The following is a description of a gene set: from publication Yevshin I, Sharipov R, Kolmykov S, Kondrakhin Y, Kolpakov F (PMID 30445619) Genes containing one or more binding sites for (SRSF9) in their promoter regions (TSS -1000,+100 bp) as identified by GTRD version 20.06 ChIP-seq harmonization. Human Gene Set: SRSF9_TARGET_GENES studied in species Homo sapiens, and this is the list of marker genes: POLN, SMC3P1, FBXO4, C2orf74-AS1, SNORD12, SNORA57, WAC, HCG15, CEP112 (centrosomal protein 112), ZFYVE16, RAD18, TXNDC9, LINC01089, VPS52, PRR11, TUBE1, KDM7A, RNY1P10, EMB, ANKRD66, ARSG, SPO11, RPS17P7, LUC7L3, DEK, MT-TC (NCBI Gene Id 4511), RNU4-75P, RN7SL638P, ACSM3, ZNF638, DTNB, IFT80, CENPK, ACIN1, RNU1-109P, NUSAP1, KRTAP1-3, GORASP2, FCHO2-DT, CYP27A1, PTPRK, DENND4A, PGBP, CNOT4, CDH8, HISLA, RNU6-1153P, RNU4-84P, RN7SL700P, TIA1, FOXG1, PLK4, IGLV3-4, NIF3L1, ANKRD44, GPATCH8, MAP2K6, EIF4B, NARF, RN7SL162P, ATP6V1G2, CSRNP3, TTL, ZNF680, COL21A1, CYP3A43, IFI44L, LINC00540, SETDB1, ARMT1, RPS2P48, RN7SL577P, RAD51B (NCBI Gene Id 5890), LTBP1, TXNL4AP1, KLHL31, SNORD117, ENSG00000201003, FKTN, LINC00972, SUPT20H, ZFYVE1, METTL8, SEC63P1, GS1-204I12.4, MIR4295, OXA1L, PSMD1, CACNA1I (calcium voltage-gated channel subunit alpha1 I), ENSG00000213963, CRKL, CLASP2, MT-CO2, RNU6-784P (NCBI Gene Id 106481428), IQUB, NOVA1, MSH2, CLSPN, TMBIM6, MIR100HG, ENSG00000235779, RN7SL510P, SYNE1, HECTD1 (HECT domain E3 ubiquitin protein ligase 1), DUSP5P1, XPO6, CAB39L, SCN3A, CCDC28A-AS1, CHTF8, TRAV32, KMO, MIR3156-1 (microRNA 3156-1), KRT8P43 (NCBI Gene Id 100293614), LINC01932, ETAA1, GPER1, SPAG16, RBM26, EGLN3, TTC21B, AHSA2P, TUSC3, SNX29, JAM2, EGFEM1P, SEPTIN1, NXPH1, LITATS1, A2M, FRMD6, TMEM123, MROH2A, SAP130, NDUFAF7, MIR340, LINC02032, LRRK2, OR2AP1, HMGN2P6, ASPH, STK38, ANGPTL4, ADAT2, HSPD1P13, DUSP22, MIA2, BAK1P1, TNPO2, MARCHF7, RNU1-101P, RPGRIP1, IRAG2, TRIM25, HECTD2, REV1, BCL2L2, GAS5, RPL36AP38, ARHGAP24, PPP3R1, MCEE, HMGN2P46, TTC29, TIAL1, RPL21P26, LINC02814, RNF212B, C12orf42, KBTBD6, FDFT1, NBAS, RNU1-131P, TRAPPC12 (trafficking protein particle complex subunit 12), CTNNB1, SNORA70 (NCBI Gene Id 26778), GCFC2, CEP170, FA2H (NCBI Gene Id 79152), RAPGEF2, GNL2, TNPO1, MIR1972-1, OR7E13P, PIRAT1, CDK5RAP2, MTRF1L, EPC2, ENOPH1P1, VPS26CP1, TUBAP13, OR2T4, FCF1P6, OR4F15, ATG12, ERI2, METTL23, ABHD4 (abhydrolase domain containing 4, N-acyl phospholipase B), MLIP-AS1, CNTLN, RFPL1S, TC2N, DHRS2, ARHGAP5, SGCA, LIMS2, MALAT1, IMPDH1P7, SRBD1, BCAS3, DICER1, RPL22P1, LRBA, R3HDM1, CARD6, MTCO3P12, MTA3, NOVA1-DT, MT-TT, SMIM14-DT, LRP1B, BCL2L2-PABPN1, LRP3, NOP58, ROCK2, MT-TR, DSG1, ARHGDIA, RNU6-1136P, SF3B1 (splicing factor 3b subunit 1), CCNG1, CCND3, DSTN, XRN1, STK33, GIRGL, IGHV3-38, ASB5, MIR4424, PIKFYVE, FRY-AS1, RNF220, FAT3, RPS3AP11, SNAP25-AS1, CCNT2, TUBD1 (tubulin delta 1), FAM184A, GNG4, GLG1 (golgi glycoprotein 1), ENSG00000260277, LYRM4, PRRX1, SNORA59B, UBE3C, ITCH-AS1, MED6, KLRF1, OR4K15, TMPRSS11GP, SGIP1, UQCC1, PPIL3, SETP12, TAPT1 (transmembrane anterior posterior transformation 1), DCAF17, MT-ND5, ROBO3, CTAGE14P, RPL23AP70, ITSN2, ARHGAP26, EWSR1, FLACC1, VPS13D, C16orf87, RNU7-133P, RPS8P6, CDC42BPA, CLEC14A, SESN1, TAF5, RAP1B, IDNK, MTND4P26, KDM3A, NFKBIL1, SPART, SCN1A, NSMCE2, ITPR2, PPIEL, RBBP9, SLC25A32 (solute carrier family 25 member 32), ATP5MGP3, EPPIN, SC5D, FAM117A, RNF103, RPL31P30, HIBCH, BPHL, RNU6-75P, CD44, KCNMB3, DCN, CRYGGP (NCBI Gene Id 1424), GPRC5D-AS1, FTO, NF1P6, SNORD22, POLR2A, SLC25A27, RBM39, M1AP (meiosis 1 associated protein), LINC00310, SRSF10P2, RNA5SP145, ERICH3, PTHLH, UNC80, KRT223P, LINC00641, AKAP5, RNU6-812P (RNA, U6 small nuclear 812, pseudogene), MTRR, SLC10A5P1, MTIF2, HEATR5A, YWHAB, TMEM212-IT1, ACACB, DDX46, LPIN1, RNU6-445P, HEATR6, FIBCD1, ANKHD1, LRRC59, SEPHS1P6, RNU7-196P, RN7SL283P (NCBI Gene Id 106479325), PTPN9, SLC25A13, CEP83, SPTLC1P1, PDZD2, UNC50, ZC3H6, PCGF1, MTND3P10, USP8, HSBP1L1, MIRLET7F1, MKRN1, SEPTIN7P14, PLPP3, SLC38A10, ACOT13, OR2E1P, MDM4, CHD1L, ERCC6L2, POLE4, G2E3, OR11H7, ESPN, ENSG00000237464, MT-TE, LINC02458, TEX41, KRTAP7-1, SSB, CCDC34, NIBAN1, MICU2, RNU1-139P, CREB3L2, CLUL1, MIRLET7A1HG, POLR1D (NCBI Gene Id 51082), SPECC1L, BRCA2, DPRXP1, GTF2I, SETD5, RFX3, SNORD12B, ENSG00000283674, DRD3, MFSD11, GRIP1 (NCBI Gene Id 23426), HELZ, DLX2, EXOC4, SLC27A1, MT-TA, BIN2P2, GSDMA, NPM1P41 (NCBI Gene Id 100422249), LIFR, MPZL3, RNA5SP98, OCIAD1-AS1, TAF11, LRPPRC, SHC1, FST, RPL29P8, GAS2, YAF2, RNA5SP73, DTNBP1, STAU1, KIF28P, TEX14, DBF4P3, GAD1, CALR3, RHOBTB3, ILF2P2, TRIM37, STIL, OR4K5 (olfactory receptor family 4 subfamily K member 5), STRN, NOL11 (NCBI Gene Id 25926), NEXN-AS1, ASH2LP2, WDR54, FCHO2, DERA, TRAV3, RICTOR, MTND2P23, ICA1L, SNORA2C, KDM2B, KLF9, CHGB, TMEM237 (NCBI Gene Id 65062), LRP10, FMC1, TOX4, ATRAID, AGL, B3GALT1-AS1, NFE2L2, RIOK3, SMIM14, KRT19P6, ST7, MT-ND4, DMXL1, KCTD20, CLIC1, NCOA3, CLASP1, VPS50, SCPPPQ1, UNK, LINC03079, PROCR (NCBI Gene Id 10544), RUFY3, UBE2NP1, CYP1B1-AS1, PSMB5, TAF8, NDUFA5, LINC02354, ADGRF5, BRK1P2, RNU6-374P, OXA1L-DT, ATAD2, PHACTR2, ST3GAL3-AS1, MT-ND6, TRDN, MIR3974, STAT4-AS1, MNAT1, PTMAP1, NOX5, CHODL, CSE1L, NUP214, DIABLO, KCNK1, NEAT1, ZNF736P6Y, BAGE2, ZMYND11, YTHDC2, MTND4LP14, ZNF90, BFSP1, CCDC150, CANX, PCDH9-AS1, TRAV10, GTF2A1, BAZ1A, SPTBN1-AS2, DNAH6, ATP13A3, RSPH14, PLPBP, STAM2, PALMD, KIAA1328P1, LNCAROD, OR5AP2, EFHC1, RALGAPA1, CRYZL1, USP37, C2orf74, MIR3938, RPL7AP74, ARID5B, CCR10, SLC25A46, CSKMT, SLAMF6P1, MTREX, IGHVII-74-1, NGDN, RNU6-827P, SPDYA, PNPLA1, MIR4734, FN1, H4C2, C6, UTRN, CTNND1, RNA5SP483, MIR4307, OR4F6, ACKR4, FBF1, MT-TF, WDR43, BAZ2B, PAAF1, ZSCAN32, ITCH, CCNG2, MIR4477A, AP3S1, NUP98, PLA2R1, STPG4, POLR3E, MAP9, RMDN2, CAVIN2-AS1, UTP4, FABP5P4, M6PR, USF3, MAPRE1P2, MIPOL1, MT-ND3, LINC02890, PAIP1, TRAV25, PLN, NPIPB2, RNU6-636P, SKA3, TFB1M, TSHZ2, RANBP17, MINAR1, MYOM2, DDX42, FGFBP3, MTND4P25, MIR1302-3, EPB41L2, ZCCHC4, RN7SL269P (RNA, 7SL, cytoplasmic 269, pseudogene), LMAN1, MT-RNR1, PPP1R21, MIR449C, L3MBTL3, FGGY-DT, KBTBD2, RPL23AP36, AKR1E2, TXNDC16 (NCBI Gene Id 57544), GPM6A (glycoprotein M6A), TTC6 (tetratricopeptide repeat domain 6, NCBI Gene Id 319089), SESTD1, UQCRB, PDE4B, KLRG1, COX6CP8 (cytochrome c oxidase subunit 6C pseudogene 8), MAGEF1, PRMT7, NDUFV2, NPL, MDM2, TRAV8-4, NKTR, DPY19L4P1, PCBP1-AS1, VIRMA, TK2, FAM133EP, HNRNPA3P17, CENPN-AS1 (NCBI Gene Id 107984858), AIDAP1, CNTNAP4, CLTC, TMC4, DTYMK, SLC25A36, IL18R1, ADAM18, RN7SKP64, NDUFAF5, AZIN1, UBE2W, ZC3H7A, GEMIN2, SRP68, CENPC, LINC02265, MTND5P12, TMEM14B, SLC7A5P2, TTLL4, TRAF3IP2, UACA, FMC1-LUC7L2, ENSG00000228697, DYNC1LI2, GPC5, CCNL1, MLXIPL, RAD50 (RAD50 double strand break repair protein), MIR4804, RPL41, FMO5 (NCBI Gene Id 2330), PHGDH, GTF2A1-AS1, OR7H1P, ABCA5, ASB3, BTN3A1, ATR, ITFG1, CARHSP1, OR1L4, MTCO3P47, POP5, TRAV22, VPS13C, MLLT10, BVES-AS1 (BVES antisense RNA 1), HNRNPA1, MAILR, EML4, PCSK2, LINC01719, CFAP54, EYS, STAMBP, WTAP (NCBI Gene Id 9589), SYT17, ABCB1, ITGA4, RNU2-45P, MTCO1P17, USP3-AS1, KRTAP19-8, NARF-AS2, RBMS1, SCN2A, DYNC1I2, CACNA1A, USP53, HNRNPC, RPP30, USP34, PRL, TASOR2, ZC3H8, HCG22, LATS1, FARP2, SLC22A10, RPL31P28, MIR99AHG, WEE1, BRD7, CYLD, DAP-DT, SUMO4, DYNC1LI1, ZNF184, NSMCE1, C11orf98, ZFHX3, HNRNPA3, ENSG00000202335, TRPS1, RPL21P5 (NCBI Gene Id 641613), GNPAT, EHBP1, SKAP1-AS2, CPS1-IT1, TUT7 (NCBI Gene Id 79670), USP32, RPL21P62, PAXBP1 (PAX3 and PAX7 binding protein 1), TTN-AS1, PRKG1, MT-ND4L, SLC35F5, GSPT1, TINAG, NAA20, TRIB3, WDR59, CSN2, PPFIBP1, PDE3B, ACTG1P22, WWP1, ZNF133, EVI5, BPTF, PAPPA, RNU6-541P, RN7SKP83, BRCA1, CNOT7, MORF4L2, SYNRG, MTFR1, CUTC, MARK2P15, ZC3H12A, SIRT5, MTND5P11, SMG1P3, NLN, MANF, DOCK7, CKS1B, C6orf132, IL1RL1, SRP54, APOH, ZRANB3, HIP1R, FOXA1, FBXO9, CEP76, VPS29, UBE2E3, RNA5SP92, OPRL1, MBD5, IDH1, LINC02612, PDCD10, ATG12P1, CNTD1, CSNK2A1, AGXT2, CFLAR, TRPC4AP, LRRTM4, UGGT2, ETV1, ZNF846, TP53RK, RNU6-651P, BLCAP, PAPPA-AS2 (PAPPA antisense RNA 2), NEXN, DLL1, MAN1A1, MIR6812, MIR646HG, UBQLN1, UBA5, SMIM15P2, FAM32DP, ZMIZ1-AS1, PDE5A (phosphodiesterase 5A), MIR548E, CLOCK, ITGB6, RNU6-663P, GLYAT, MT-CYB, CXCL13, SLC16A3, CENPBD2P, LINC00607, MED28P3, ATP6V1G2-DDX39B (NCBI Gene Id 100532737), RN7SKP117, C2orf92, FGF14, HERPUD1, MT-TD, LINC00929, WDR35, FAM120B, PKN2, ZNF512B, FBXO33, SELENOI, KIAA0319L, SLC5A6, KIF15, PRKCH, SNORD11B (NCBI Gene Id 100113392), SCFD1, MT-TL2, CHORDC1, ATP6V1H, ZNF385B, THAP12P5, ADGRG6, PSMD14, GARS1P1, WRN, SKIC3, ENSG00000232053, ANKRD17, PARD3B, TMPRSS15, ADSS2, SNX5, TDRD15, NEPRO, TRAV38-2DV8, ABCC3, FSIP2, RSF1, CAP2, SF3A3P1, ERMARD, CCDC88A, SYF2P1, ABHD13, INTS9, PLA1A, SNORD77B, AMBP, RNA5SP177, GCN1, MIR29B2CHG, N4BP2L2, PRR11P1, FAM230J, PREB, RNA5SP49, ANO5, SLC17A1, GATA5, NFATC4, MAP3K5-AS1 (MAP3K5 antisense RNA 1), PARP2, LPCAT2, GOLGA4, BABAM2 (BRISC and BRCA1 A complex member 2), RNU6-1277P, SGO2, HNRNPLL, FAP, CLLU1-AS1, CCDC68 (coiled-coil domain containing 68), PDS5B, CCP110, SCN1A-AS1, RYK, NBPF1, NSFL1C, ABCA9, PACRGL, PRP4K, USP3, CRYM, CHEK1, SLU7, LHX8, TSGA10, ACAT2, PTP4A1, STARD3NL, LINC01088 (NCBI Gene Id 100505875), BCAS1, SLC7A7, FAM177A1, HELZ-AS1, EXOSC3, PARN, LDHAP3, MT-TN, DARS2, SPAG9, MIR1291, ANGEL2, MT-TY, AP4E1, OR7E62P, WDPCP, RNASE11, LINC02488, GPS2, OSBPL9, ATXN2, MTND6P4, OR4K2, ALG8, REPS1, TM7SF3, PITPNM1 (phosphatidylinositol transfer protein membrane associated 1), LINC00836, CIDEB, ZBTB4, H3C9P, MAP2, CDCA2, GPHN, NPHP3, RPS3AP7, CNTNAP1, DBIL5P2, PRKD3, DBF4P2